The following is a description of a gene set: Any of the heteromeric enzymes that act in the TCA cycle. Human Gene Set: GOCC_TRICARBOXYLIC_ACID_CYCLE_HETEROMERIC_ENZYME_COMPLEX studied in species Homo sapiens, and this is the list of marker genes: ABHD11, OGDHL, SUCLG2, KAT2A, BCKDK, IDH3B, KGD4, DBT, OGDH, SUCLG1, IDH3A, SUCLA2, DLD, DLST, IDH3G